The following is a description of a gene set: Mouse Gene Set: MIR_8103 studied in species Mus musculus Genes predicted to be targets of miRBase v22 microRNA mmu_miR_8103 in miRDB v6.0 with MirTarget v4 prediction scores > 80 (high confidence targets). from publication Chen Y, Wang X (PMID 31504780), and this is the list of marker genes: Rad54b, Pgrmc2, Vsnl1, Meis1, Edn3, Zfp980, Zfp433, Zfp963, Laptm4a, Pitpna, Kcna6, Exoc5, Pla2g3, Prr23a4, Slfn9, Vkorc1l1, Zfp942, Adamts5, Gm14322, Zbtb6, BC107364, Tmem237, Gm14308, Rex2, Gm2026, Zfp820, Zfp758, Mical3, Eif4e, Zfp935, Trpm2 (transient receptor potential cation channel, subfamily M, member 2), Sec16a, Zfp994, 2210418O10Rik, Zfp120, Cdh7, Zkscan1, Prpf39, Nr2c2, Shtn1, Bcl2l2, Zfp729b, Zfp944, Lcorl, Atg12, Rbak, Nkd1, Zfp936, Cd40, Acer2, Zfp981, Slc50a1, Sgo1, Zfp995, Zfp871, Matn2, Zfp966, Ccnj, Ppp2r2d, Nsdhl, Ptprr, Lrrc55, Ccdc50, Zfp600, Klhl29, Zfp946, Zfp386, Zfp616, Ccr3, Zfp967, Tnn, Usp8, Klhl13, Mapre1, Elovl5, Ric8a, Vps37a (NCBI Gene Id 75907), Gm14326, Gm14325, Zfp970 (NCBI Gene Id 628308), Atxn1, Itga10, Gm14434, Gm4724, Zfp965, Map2k4, Gm14296, Gm14391, Zfp1009, Scml2, Spring1, 1700123O20Rik, Cnot4 (CCR4-NOT transcription complex, subunit 4), Nsd1, Sfpq, Atp2b2, Zfp738, Zfp973, Gm6710, Pisd, Parp11 (NCBI Gene Id 101187)